Given this list of marker genes ZNF408, TREX1, LRP5, TSPAN12, CTC1, MAX, DUX4, DUX4L1, FZD4, POT1, SMCHD1, NDP, DNMT3B, TINF2, FRG1, here is a description of the gene set: studied in species Homo sapiens Human Gene Set: HP_RETINAL_EXUDATE Retinal exudate Fluid which has escaped from retinal blood vessels with a high concentration of lipid, protein, and cellular debris with a typically bright, reflective, white or cream colored appearance on the surface of the retina.